Given this list of marker genes Notch1, Stxbp3, Adra2a, Trim9, Gnai2, Rest, Syt4, Rap1b, Pou5f1, Cbarp, here is a description of the gene set: studied in species Mus musculus Any process that stops, prevents, or reduces the frequency, rate or extent of calcium ion-dependent exocytosis. Mouse Gene Set: GOBP_NEGATIVE_REGULATION_OF_CALCIUM_ION_DEPENDENT_EXOCYTOSIS